Given this list of marker genes PDGFRA, COBLL1, ADAMTS15, FGFR1, BMP4, PAX9, WNT10A, NECTIN1, DLX3, WNT10B, CDC42BPB, NEK1, CDH1 (NCBI Gene Id 999), DLX4, SUMO1, B3GLCT, AXIN2, ARHGEF38, NAA10, MSX1, GLI2, EDARADD, ARHGAP29 (NCBI Gene Id 9411), ERCC3, IRF6 (NCBI Gene Id 7452), BLM, RIPK4, EIF4A3, TGFA, CDH11, TP63, EDA, RIC1, BCOR, LRP6, DLG1, here is a description of the gene set: species: Homo sapiens Agenesis of incisor Human Gene Set: HP_AGENESIS_OF_INCISOR Agenesis of incisor.